Given this list of marker genes TBILA, TNKS2, MEST, STON2, ZNF616, DPYD, CPLX1, SLC35G1, NAPEPLD, GPR87, ENSG00000291065, PDAP1, CDH11, SERPINE1, ISOC2, LRWD1, TMEM168, INPP4B, OGFRL1, IL15, SLC27A2 (solute carrier family 27 member 2), MED13L, ARHGAP26, UGCG, CYP2U1, EVA1A (NCBI Gene Id 84141), CCBE1, FHL1, RCL1, ANKRD33B, ATF3, IL7R, METTL21A (NCBI Gene Id 151194), LAMB3, NLN, AHCYL2, CCSER2, LHX6 (NCBI Gene Id 26468), FAM200A (NCBI Gene Id 221786), ACACB, RFWD3, KLHL29, ID3, ASNS, CLCN4, GLIPR1, FUT8-AS1, ADGRG6, STRIP2, KLHDC10, SNAI2, TBL1X, TRIP6, MEGF6, WASL, LINC02249, BAIAP2L1, DPY19L2P2, SYT1, MAP3K14, CDA, PEG10, RGMB, SOX30, MYO6, IL31RA (interleukin 31 receptor A), SUGT1, RUNX2, PCGF5, ARHGAP18, PI3, CERT1, LY6E (NCBI Gene Id 7999), RESF1, TNPO3, JCAD, FLNC, PMPCB, FGF5, MRPS25, SMKR1, IL32, LPXN, ANXA3 (NCBI Gene Id 306), RBP7, IL6ST, PRR5, PODXL, NEXN, ZNF385D, PPP1R35, TGFA, ENDOD1, ADAMTS6, KRTAP2-3, CALB1, here is a description of the gene set: Genes up-regulated in PC-3 cells (prostate cancer) stably expressing ST7 off a plasmid vector. from publication Hooi CF, Blancher C, Qiu W, Revet IM, Williams LH, Ciavarella ML, Anderson RL, Thompson EW, Connor A, Phillips WA, Campbell IG (PMID 16474848) studied in species Homo sapiens Multiple lines of evidence have provided compelling evidence for the existence of a tumor suppressor gene (TSG) on chromosome 7q31.1. ST7 may be the target of this genetic instability but its designation as a TSG is controversial. In this study, we show that, functionally, ST7 behaves as a tumor suppressor in human cancer. ST7 suppressed growth of PC-3 prostate cancer cells inoculated subcutaneously into severe combined immunodeficient mice, and increased the latency of tumor detection from 13 days in control tumors to 23 days. Re-expression of ST7 was also associated with suppression of colony formation under anchorage-independent conditions in MDA-MB-231 breast cancer cells and ST7 mRNA expression was downregulated in 44% of primary breast cancers. Expression profiling of PC-3 cells revealed that ST7 predominantly induces changes in genes involved in re-modeling the extracellular matrix such as SPARC, IGFBP5 and several matrix metalloproteinases. These data indicate that ST7 may mediate tumor suppression through modification of the tumor microenvironment. Human Gene Set: HOOI_ST7_TARGETS_UP